The following is a description of a gene set: Complex III assembly Mouse Gene Set: REACTOME_COMPLEX_III_ASSEMBLY studied in species Mus musculus, and this is the list of marker genes: Cyc1 (cytochrome c-1), Fxn, Uqcrc1, Nfs1, Uqcrfs1, Lyrm7, Ttc19, Hscb, Uqcrh, mt-Cytb, Uqcrc2, Uqcrq, Hspa9, Iscu, Lyrm4, Uqcr10, Uqcrb